Given this list of marker genes ELAVL2, VRK2, MACC1, ZFR, CDK13, PAFAH1B2, STX2, CYP26B1, FAM91A1, LPAR3, PGRMC2, OPA3, MYH10, PITX2, DSTYK, MBNL3, PPARA, HCAR3, C5orf24, PAPPA, MSANTD4, H2AZ1, ALS2, MCIDAS, MPHOSPH9, ARRB1, ANP32E, TMEM135, LYSMD3, SUGT1, HDAC4, NR2C2 (nuclear receptor subfamily 2 group C member 2), LYPLA1, PRRG1, CTNND2, PAQR9, NAP1L2, SCUBE2, RAP2C, ZCCHC3, TSEN2, BBS10 (NCBI Gene Id 79738), FAM24A, GSN, HSDL1, RHEB, WWTR1, FBXL2, HOXC13, C6orf120, RBM20, MFF, BNC2, SOBP, SLC14A1, PIKFYVE, MPZL2, NEK6, PTCH1, SLC23A2, QSER1, EPN1, CRLF3, CDKN3 (cyclin dependent kinase inhibitor 3), NBPF15, SFPQ, PHYHIPL, WDR33, GJC1, HMG20A, FOXJ3, TRHDE, AP3S1, WDFY3, TNRC6B, KIDINS220, IKZF2, EDEM1, IFNAR1, NCKAP5 (NCBI Gene Id 401013), GRB2, KIF17, NUFIP2, TPK1, GIGYF1, LHX6 (LIM homeobox 6), ZEB2, PCDH9, KCTD20, KLF12, HS6ST3, RNFT1, TADA1, HCN1, GCNT2, ZEB1, AQP11, MAPK6, MBNL1, FNIP2, HCAR2, HS6ST2, CCNE2, SUPT6H, CREBRF, REEP3, CD2AP, NBPF14, FNBP1L, SLC1A7, RBM12, NIPAL3 (NCBI Gene Id 57185), E2F3, RARB, RANBP6, RAB10, TCF4, RBM46, CDC42EP3 (CDC42 effector protein 3), ZNF416, JAG1, TMEM41B, CEP120, FOXA2, USP49, GLCCI1, SMIM15, DEK, DCUN1D3, PPM1E, RASSF8, CLASP2, GLS, RSL24D1, CHD2, FKBP1A, FKBP5, HMGCS1 (3-hydroxy-3-methylglutaryl-CoA synthase 1), UGT1A1, TMED9, SEMA6A, HIPK3, TGFB2, ERG (NCBI Gene Id 2078), CREB1, VCAN, MAP2K4 (NCBI Gene Id 6416), INO80D, ABL2 (NCBI Gene Id 27), ZCCHC24, RSAD2, FAM168B, STXBP5, MAP3K19, UGT1A4, ZYG11B, KCTD3, ARPC5, UGT1A9, NRIP3, GABPB1, ANGPTL1, CCDC6, RBM24, DUSP3, FMR1, TMEM130, EGR2, IRS2, PLXNA4, RNF145, TRUB1, RBM33, FAM210A, MIER3, SLC20A1, CRMP1, ZBTB34, PRELID2, LGR4, DR1, RALGPS2, UNC5C, BICD2, NRXN1, MAP7D1, NTNG1, PHLPP2, B3GNT5, TRAM1, IKZF5 (NCBI Gene Id 64376), GAB1, IBA57, ZNF705EP, DAPK1, PLAGL2, RAB38 (NCBI Gene Id 23682), PHC3, BRD3, CERS6, MN1, RAPGEF5, ZNF284, ENSG00000275993, HNRNPF, APBB2, C21orf91, PLAG1, MNX1, DNAJC13, EVI5L, TCF24, ACO1, MINDY3, SIK1, YWHAG, PRKACB, MYRIP, SLC16A7, CORIN, TSHZ3, SLC30A4, MAP3K2, TMEM170B, ACOT7, PIN4, PIAS2, SAMTOR, PRR11, NBPF8, TSC1, YTHDF2, MYBL1, RIMS1, KMT2A, MARCHF6, CDC25A, PURA, GPC2, KIF3A, KAZN, ABHD18, PFKM, MIER1, ACADSB, TIAM1, MDM1, UBE3A, EPHA2, CCDC85C (NCBI Gene Id 64758), NME1, SCHIP1, BRMS1L, TP53INP1, CBL, C11orf54, ST3GAL3, CXCL12, IPO5, TNS3, OSBPL11, DLC1, GSG1, SOCS5, CDK8, MAP3K20, PIGA, SPRYD3, HGF, FHIP2A, ARHGEF18, DCP2, LOXL3, ATXN7, PPM1L, PRKCE, NBPF9, IQCJ-SCHIP1, SRC, PTPRG, CCND2, C14orf28, GNA13, ATXN1, HEATR5A, TCERG1 (NCBI Gene Id 10915), ERC2, TTR, KLHDC10, NCOA2, ANKRD44, IL6R, TMTC1, LSAMP, TAF12, SDC2, SESTD1, FAT3, TOMM7, GPAT4, SLC19A2, ALKAL2, NR3C1, C2orf69, HIC2, PPT2, PEG3, MAPK10, PDGFRA, PDCD4, C6orf141, NDFIP2, RSPO2, CDC14A, TNS1, MLANA, SCD5, JAGN1, SCN2B, NUCKS1, NBPF20, PDK2, STON2, RCOR3, ZNF644, MED6, C5orf63, KHDRBS3 (NCBI Gene Id 10656), NFASC, SLAIN2, PLEK, TFAP2C, KLF6, SMC5, CSTA, TCF12, MYT1L, NBPF11 (NCBI Gene Id 728912), WNK1, SLC35D1, LHFPL6, PCDH10, KAT6B, EPHA7, DMWD, LTBP1, SPOPL, ATL1, ITGA6, ELK3, OLFM1, ARFGEF3, IFFO2, NPAS3, P2RY1, PLCL1 (phospholipase C like 1 (inactive)), CDC25B, URGCP, JAZF1, AK2, ITPRIPL2, IGDCC4, LPP, TNFAIP3, EGFR, HYCC2, XPR1, CALCR, RB1CC1, UGT1A6, HS2ST1, CEP43, YAP1, ELMOD1, DOCK4, UGT1A3, TTLL7, CFAP20DC, C1orf21, ASTN1, SMIM7, CHP1, LMBR1, XKR9, ATP8A1, CCDC80, TTBK2, KIAA0408, TMPRSS11F, GPR6, STXBP1, ATP8A2, BEAN1, ARL4A, RAB8B, SPAG9, EXOC5, CNTN1, here is a description of the gene set: species: Homo sapiens from publication Chen Y, Wang X (PMID 31504780) Human Gene Set: MIR141_3P Genes predicted to be targets of miRBase v22 microRNA hsa-miR-141-3p in miRDB v6.0 with MirTarget v4 prediction scores > 80 (high confidence targets).